Given this list of marker genes Smarca1, Smarca5, Smarca4, Smarca2, Smarcad1, here is a description of the gene set: Mouse Gene Set: GOMF_HISTONE_OCTAMER_SLIDER_ACTIVITY A chromatin remodeler activity that slides core histone octamers along chromosomal DNA. species: Mus musculus